Given this list of marker genes Colec12, Scarf1, Lsr, Stab2, Pcsk9, Trem2, Cdh13, Msr1, Ldlr, Scarb1, Samd1, Pltp, Crp, Cd36, Lipc, Thbs1, Sorl1, Stab1, here is a description of the gene set: studied in species Mus musculus Binding to a low-density lipoprotein particle, a lipoprotein particle that is rich in cholesterol esters and low in triglycerides, is typically composed of APOB100 and APOE, and has a density of 1.02-1.06 g/ml and a diameter of between 20-25 nm. Mouse Gene Set: GOMF_LOW_DENSITY_LIPOPROTEIN_PARTICLE_BINDING